The following is a description of a gene set: studied in species Mus musculus Any process that decreases the rate, frequency or extent of a type I interferon-mediated signaling pathway. Mouse Gene Set: GOBP_NEGATIVE_REGULATION_OF_TYPE_I_INTERFERON_MEDIATED_SIGNALING_PATHWAY, and this is the list of marker genes: Oas1g, Usp18, Oas1d, Smim30, Adar, Oas3, Stat2, Oas1h, Oas1c, Trex1, Oas1b, Cnot7, Cactin, Ythdf3, Ythdf2, Dcst1, Oas1e, Ttll12, Isg15, Gigyf2, Ptpn2, Mettl3, Mmp12, Oas1a, Oas1f, Nlrc5, Eif4e2, Samhd1, Mavs, Mul1